Given this list of marker genes Ticam2, Arg2, Sirpa, Oas3, Mul1, here is a description of the gene set: Mouse Gene Set: GOBP_NEGATIVE_REGULATION_OF_CHEMOKINE_C_C_MOTIF_LIGAND_5_PRODUCTION studied in species Mus musculus Any process that stops, prevents, or reduces the frequency, rate, or extent of production of chemokine (C-C motif) ligand 5.